Given this list of marker genes Foxh1, Ccm2l, Tpm1, Kcnj11, Tnni3, Myl2, Pou4f1, Mybpc3, Tgfbr1, Smad7 (SMAD family member 7), Dsg2 (desmoglein 2), Eng, Heg1, Naglu, Rxra, Nkx2-5, Ednra, Mecp2, Med1, Zfpm2, Chd7, Tgfbr3, Ppp1r13l, Tnni1, Epor, Tnnc1 (NCBI Gene Id 21924), Myh7, Zmpste24, Nog, Ryr2, Bmpr1a, Fkbp1a, Dsp, Smad4, Tbx5, Hey2, Tnnt2, Col11a1, Notch1, Dll4 (NCBI Gene Id 54485), Myl3, Kcnj8, Lrp2, Ly6e, Tgfb1, Col14a1, Foxc1, Isl1, Hand1, Prox1, Nrg1, Klk1b1, Foxc2, Bmp10, Hey1 (hairy/enhancer-of-split related with YRPW motif 1), Mbd3, Ube4b, Myh6, Pkp2, Id2, Irx3, Epo, Mbd2, Tgfb2, Fgfr2, Adamts9, Tbx3, Ptcd2, Rbpj, Ctnnb1, Gata4, here is a description of the gene set: The process whose specific outcome is the progression of ventricular cardiac muscle over time, from its formation to the mature structure. studied in species Mus musculus Mouse Gene Set: GOBP_VENTRICULAR_CARDIAC_MUSCLE_TISSUE_DEVELOPMENT